Given this list of marker genes YWHAG, XPO1, CDKN2A, YWHAZ, HDAC2, MITF, CTNNB1, KRT1, HBP1, DKK1, INCENP, CHD8, CBY1, CCND2, RUVBL2, CDX1, TCF7L2, LEF1, MYC, CDX4, TBL1XR1, CCND1, YWHAQ, SMARCA4, TERT, TLE5, YWHAB, ADCY7, IGF2BP1, TNIK, SSPOP, CACNA1G, TCF4, CTBP1, MED12, SALL4, CXCL8, TBL1X, TLE1, KCNIP4, TCF7 (transcription factor 7), SNAI2, TLE2, TBXT, AXIN2, BCL9, CTNNBIP1, MT-CO2, FGF4, CUL1, MYF5, SFN, DVL3, KLF4, CDH1, HDAC1, CAMK4, VCAN, YWHAE, ZCCHC12, DKK4, MDFIC, TLE4, JUN, MMP9, SKP1, SP5, EP300, NEUROG1, MYOG, MMP2, CCN1, TRRAP, ID2, AR, APC, YWHAH, TCF7L1, PITX2, NCOA2, here is a description of the gene set: Human Gene Set: PID_BETA_CATENIN_NUC_PATHWAY Regulation of nuclear beta catenin signaling and target gene transcription from publication Schaefer CF, Anthony K, Krupa S, Buchoff J, Day M, Hannay T, Buetow KH (PMID 18832364) studied in species Homo sapiens